Given this list of marker genes Cap1, Clca2, Ier5, Abcb7, Ifi203, Tfrc, Xlr4b, Rab6b, Uap1, Serinc1, Epb41l2, Pals1, Atp1a2, Ido1, Rad51ap1, Asph, Vps53, Slc25a24, Trim34a (NCBI Gene Id 94094), Sc5d, Cited1, Pdgfd, Thbs1 (NCBI Gene Id 21825), Cryab, Jak1, Amacr, Hif1a, Mpzl2, Tmem30b (NCBI Gene Id 238257), Nr1d2, Btbd1, Angel2, Lin7c, Cdh11, Rnf14, Syt13, Galc, Ifi202b, Nabp1, Hgf, Akr1b1, here is a description of the gene set: Mouse Gene Set: HOWLIN_CITED1_TARGETS_1_DN Expression microarray analysis identified CITED1 among a group of genes specifically upregulated in the pubertal mouse mammary gland. At puberty, CITED1 localizes to the luminal epithelial cell population of the mammary ducts and the body cells of the terminal end buds. Generation of CITED1 gene knockout mice showed that homozygous null mutants exhibit retarded mammary ductal growth at puberty and, in addition, dilated ductal structures with a lack of spatial restriction of the subtending branches. Analysis of CITED1 homozygous null and heterozygous null mammary gland gene expression using microarrays suggested that the mammary-specific phenotype seen in the homozygous null females is due to a disturbance in the transcription of a number of key mediators of pubertal ductal morphogenesis. These include estrogen and TGFbeta responsive genes, such as the EGFR/ErbB2 ligand, amphiregulin, whose transcription we suggest is directly or indirectly regulated by CITED1. species: Mus musculus from publication Howlin J, McBryan J, Napoletano S, Lambe T, McArdle E, Shioda T, Martin F (PMID 16278680) Genes down-regulated in mammary glands from the CITED1 knockout mice: homozygotic vs. heterozygotic animals.